Given this list of marker genes ZNF646, KLK15, JAM2, P3H3, MRPL47, LRRC18, LIM2, TANC1, DEGS1, PUS10, IGSF5, DIO2, MYO1A, TRMT112, MX2, PHKG2, RBM7, PTPN3, NUDT16, CDK14, TYW1, ABHD4, ARIH1, CYRIA, SNTA1, TMEM106B, MED19, HRG, LMO7, PPP1R11, KLF4, ATP6V1A, CDH18, NSL1, FBXO40, AMPD3, RPTN, RPL36A-HNRNPH2, ALS2, ANTXR2, RTL5, RIMS4, MMP16, ZMAT4, ZBTB46, TMEM207, ARHGAP28, SLFN13, PLXNA4 (plexin A4), CCDC186, FRMD4A, FUT11, TYW1B, CNGA1, ZBTB41, NPHP1 (NCBI Gene Id 4867), GABBR2, LMOD2, PTGFRN, LTBP2, ATP8A1, TM9SF3, RAP1A, DCLRE1A, NAV1, SLC25A33, GPBP1, TRIM10, AFDN, TCF7L2, ILRUN, LPGAT1, SLC24A2 (NCBI Gene Id 25769), PARP16, CACNA1E, SUMO1, SUCO, SSTR3, TNRC6B, MELTF, ROR1, OTUD1, SOCS7, KRT10, VGLL3, HLA-E, SHISAL1, ZNF626, BCL2L13, CFAP61, HAND2, NEK9, IGF2BP2, EIF4A3, PAQR8, KCMF1, NRXN3, ADAMTS9, PATE4, PMEPA1, IGSF9B, ANKS4B, ECHDC1 (ethylmalonyl-CoA decarboxylase 1), DTD1, SMARCD1, BRCC3, STAG2, SCML2, TIMM23B, FADS1, CACUL1, CHST2, PSG8, TASOR, ZNF254, ANKRD29, ZNF420, TMEM154, HINFP, APCDD1L, PEG10, ZNF430, NRXN2, SMC1A, RAB3C, ZNF24 (zinc finger protein 24), VEGFA, GGA3, RFTN2, BLOC1S5, EIF2B2 (NCBI Gene Id 8892), NAIF1, SLC35E4, NPM3 (nucleophosmin/nucleoplasmin 3), PRKG2, STMN1, ARHGAP6, MRPL33, C14orf132, KIAA1549, MACO1, SPATA31D4, CRISPLD1, XDH, GRIP1, AQR, NXNL2, SLTM, SRP19, THAP12, KIF5B, HNF1B, CREG1, CNGA3, TBL1XR1, SNRNP48, CD109, KCNN3, ZNF37A, SPATA31D3, CTNNBIP1, RBFOX2, SCO1, ATP11C, USP46, DNAJC21, TUSC1, FBXO45, SQLE, METTL9, RBM41, GRIA3, TFE3, TRMT44, GCSH, PMPCB, CLCN3, ATP2B4 (NCBI Gene Id 54594), EBF1, ALDOA, LDB3, PAPOLB, SCN1A, RAB20, DELE1, GCNT2, METTL6, EXTL2, ABI2, B3GALNT2, PNMA5, ZNF618, ZNF737, CHMP7, PLEKHO2, TNFSF4, EDARADD, CAMK1D, here is a description of the gene set: from publication Chen Y, Wang X (PMID 31504780) species: Homo sapiens Genes predicted to be targets of miRBase v22 microRNA hsa-miR-877-3p in miRDB v6.0 with MirTarget v4 prediction scores > 80 (high confidence targets). Human Gene Set: MIR877_3P